The following is a description of a gene set: The process in which the anatomical structure of the retina is generated and organized in a camera-type eye during the embryonic life stage. species: Mus musculus Mouse Gene Set: GOBP_EMBRYONIC_RETINA_MORPHOGENESIS_IN_CAMERA_TYPE_EYE, and this is the list of marker genes: Hipk2, Lhx1, Cdon, Prox1, Lrp6, Rbp4, Hipk1